Given this list of marker genes SRM, RAD54B, GFOD1, PLEKHA8, MRPS25 (mitochondrial ribosomal protein S25), TNS2, SLC2A6, PIM3, DIP2C, ZNF473, SLC6A6, TMEM170A, GDE1, SFRP2, ALS2, BAG2, PSMC3IP, PKIG, RAB33A, POP1 (POP1 homolog, ribonuclease P/MRP subunit), GDPD1, SGSM3, SRL, CFAP299, NR4A3, ZNF583, TBL2, CD44, ALG2, C12orf75, DUT, ABCA5, CES3, EPDR1, SLC35D1, NKAIN1, NT5DC3, RLIG1, PCGF5, PLXNA1, RPGR, PIM1, TNNI1 (troponin I1, slow skeletal type), CD83, EXOSC3, RNF125, NSMCE2, CERCAM, DOCK7, CMC2, GCH1, ZNF207, KIFC1, POGLUT2, REL, IER3, LACC1, COPZ2, COX10, ACVR1, DIS3, CPSF6, GAS2L1, TMEM25, FBXO42, CNTLN, GRP, CENPS, POLA2, BBOX1, SH3YL1, DHX36, BBS12, CEP76, SRFBP1, FAM229B, NENF, ARHGEF39, DAPK1, DNAJC12 (DnaJ heat shock protein family (Hsp40) member C12), SMIM3, NUDT2, P4HA2, BAD, NPAS4, STEAP4, RHAG (Rh associated glycoprotein), TMEM41A, CRLS1, ARMCX1 (NCBI Gene Id 51309), DDX31, SLC16A14, PLOD2, SOAT2, TMEM164, TRIP10, SLC66A1, PPP2R3C, CRABP2, JADE3, SIL1, FARP2, SLC7A11, SH3PXD2B, PXMP2, ZP1, GMDS, HDGF, MSH3, CPSF2, SLC25A33, KMT5A, PROCR, AKAP1, PAOX, FBXW8, SPIN4, EIF2B1 (NCBI Gene Id 1967), SH3BP2, MAST2, GLA, MBOAT2, ACSL6, DCAF10, MFSD14B, SAMD14 (sterile alpha motif domain containing 14), RAD54L2, PLXDC2, DENND5A, AIPL1, FIBIN, XCL1, SLC37A3, GRN, MOK, COQ7, SLC30A3, BCL3, HIRIP3, MYH10, MEX3A, ANKRD40, RBPMS2, CCDC112, SNX16, DCTPP1, LIG1, TMEM70, EFCAB2, SMPDL3B, NOC3L, TTC39B, OPN3, NINJ1, SLC34A2, ITGA2B, NEK6, ZFC3H1, NOC4L, CLPB, MLEC, PURG, TTLL12, NMRAL1, ROBO2, PCBP4, SHMT1, PPIH, RFC3, MMP10, ZBED6, SDF2L1, DPP8, UQCRQ, TNIP2, TIMP3, IL21, PELO, MOB3B, EXPH5, ENOX2, TSPAN4, CA12, ZCCHC9, PRUNE1, CCL4, TTC12, NEURL1B, SACS, HEMK1, MAPKAPK3, CKAP2, ST6GALNAC6, ZBTB37, BCAS1, PLAGL2, SLC39A6, GPRIN3, AMZ1, MED12L, here is a description of the gene set: from publication Yamada T, Park CS, Mamonkin M, Lacorazza HD (PMID 19412182) studied in species Homo sapiens Genes down-regulated in comparison of naive CD8 T cells versus activated CD8 T cells. Transcription factors that regulate quiescence, proliferation, and homing of lymphocytes are critical for effective immune system function. In the present study, we demonstrated that the transcription factor ELF4 directly activates the tumor suppressor KLF4 downstream of T cell receptor (TCR) signaling to induce cell cycle arrest in naive CD8+ T cells. Elf4- and Klf4-deficient mice accumulated CD8+CD44hi T cells during steady-state conditions and generated more memory T cells after immunization. The homeostatic expansion of CD8+CD44hi T cells in Elf4-null mice resulted in a redistribution of cells to non-lymphoid tissue due to reduced expression of the transcription factor KLF2, and the surface proteins CCR7 and CD62L. This work describes the combinatorial role of lymphocyte-intrinsic factors in the control of T cell homeostasis, activation and homing. Human Gene Set: GSE15324_NAIVE_VS_ACTIVATED_CD8_TCELL_DN